Given this list of marker genes Slc30a1, Slc39a8, Slc11a2, Slc39a2, Slc11a1, Slc39a14, here is a description of the gene set: Mouse Gene Set: GOBP_CADMIUM_ION_TRANSMEMBRANE_TRANSPORT species: Mus musculus A process in which a cadmium ion is transported from one side of a membrane to the other by means of some agent such as a transporter or pore.